Given this list of marker genes Tmem38b, Selenon, Casq2, Ryr1, Cacna1s, P2ry6, Slc8a1, Gstm7, Ryr3, Ryr2, Tmem38a, Chek1, P2ry1, here is a description of the gene set: species: Mus musculus Any process that results in a change in state or activity of a cell (in terms of movement, secretion, enzyme production, gene expression, etc.) as a result of a purine-containing compound stimulus. Mouse Gene Set: GOBP_CELLULAR_RESPONSE_TO_PURINE_CONTAINING_COMPOUND